The following is a description of a gene set: N-acetyltransferases (NATs; EC 2.3.1.5) utilize acetyl Co-A in acetylation conjugation reactions. This is the preferred route of conjugating aromatic amines (R-NH2, converted to aromatic amides R-NH-COCH3) and hydrazines (R-NH-NH2, converted to R-NH-NH-COCH3). Aliphatic amines are not substrates for NAT. The basic reaction is<br><p><b>Acetyl-CoA + an arylamine = CoA + an N- acetylarylamine</b></p><br>NATs are cytosolic and in humans, 2 isoforms are expressed, NAT1 and NAT2. A third isoform, NATP, is a pseudogene and is not expressed. The NAT2 gene contains mutations that decrease NAT2 activity. This mutations was first seen as <i>slow acetylation</i> compared to the normal, <i>fast acetylation</i> of the antituberculosis drug isoniazid. Incidence of the slow acetylator phenotype is high in Middle Eastern populations (70%), average (50%) in Europeans, Americans and Australians and low in Asians (<25% in Chinese, Japanese and Koreans). N-acetylation and methylation pathways differ from other conjugation pathways in that they mask an amine with a nonionizable group so that the conjugates are less water soluble than the parent compound. However, certain N-acetlylations facilitate urinary excretion.<br>N-acetylation occurs in two sequential steps via a <i>ping-pong Bi-Bi mechanism</i>. In the first step, the acetyl group from acetyl-CoA is transferred to a cysteine residue in NAT, with consequent release of coenzyme-A. In the second step, the acetyl group is released from the acetylated NAT to the substrate, subsequently regenerating the enzyme. part of: Phase II - Conjugation of compounds Reactome Pathway: Acetylation species: Homo sapiens, and this is the list of marker genes: NAT2 (NCBI Gene Id 10), NAT1